The following is a description of a gene set: Human Gene Set: GSE13484_12H_VS_3H_YF17D_VACCINE_STIM_PBMC_DN Genes down-regulated in comparison of peripheral blood mononuclear cells (PBMC) cultured with YF17D vaccine for 12 h versus PBMC cultured for 3 h. studied in species Homo sapiens from publication Querec TD, Akondy RS, Lee EK, Cao W, Nakaya HI, Teuwen D, Pirani A, Gernert K, Deng J, Marzolf B, Kennedy K, Wu H, Bennouna S, Oluoch H, Miller J, Vencio RZ, Mulligan M, Aderem A, Ahmed R, Pulendran B (PMID 19029902) The immune responses generated by YF-17D by profiling genes in PBMCs from 2 donors cultured with YF-17D vaccine were accessed after 3 and 12 hours., and this is the list of marker genes: C4BPB (NCBI Gene Id 725), ETV7, EEF1B2, EIF3J, CD5, HBS1L, AHCTF1, RBPMS, TGFBI, TSPAN9, RAI1, KPNA1, SP100, DLL3, ICAM1, P2RX5, KLF2, ITGAM, DCAKD, PRDX6, CDKN2D, CYB5B, MYH2, MAP3K2, HLA-DMA, MAPRE2, SPTBN1, IL1R2, CNDP2, GPN1, TPSD1, EIF4A1, BAK1, ARID5A, TSC22D3, SAMD9, MGST2, POLR3E, MIA3, KLRB1, DENND5A (DENN domain containing 5A), CARTPT, ZBTB1, ISCA1, KLHL20, PPP1CB, PVALB, PICALM, VOPP1, H2AC4, RLF, RAB3GAP1, H2BC17, B4GALT1, CRYBG1, EPAS1, EEF1A2, VPS37B, DNAJA1, TAS2R3, HCAR3, TMEM39A, RGCC, TIPIN, NDUFA9, CYCS, CLASP2, OTUD7B, KIR2DL4, GP1BA, SFXN1, COX7B, PRSS53, ATP1A1, BTG2-DT, SNRK, ZNF124, RAB29, SYNCRIP, BCL2A1, CHN2, MYD88, TMX4, RPL5, CHP1 (calcineurin like EF-hand protein 1), MTPAP, RNF103, MTX1, UTP11, RHOBTB1, MAGT1, PSAP, DEAF1, KLHDC4 (kelch domain containing 4), NFYC, AP3M2, IL4R, PSMD12 (NCBI Gene Id 5718), CCZ1B, CAMK1D, KCNIP1, STAT3, CEMP1, TULP2, RPL3, RACK1, SERPING1, RIF1, STAT4, RPL8, CLEC2D, SEH1L, DDX50, AKAP7, GNAZ, MALT1, ENDOD1, MARCHF2, RPSA, PECAM1, TOR1B (NCBI Gene Id 84822), MTHFD2L, B4GALT5, HIVEP1, RAP1GAP2, PIM1, PGK1, ZCCHC14, SCPEP1, S100A6, REPS2 (NCBI Gene Id 9185), IL18R1, PXN, ERCC6L, GBP2, SLC25A32, SH2B3, ARL4C, CD36, GSPT1, CAVIN2, GPR65, PRNP, MIR22HG, PMAIP1, IL1A, IRGQ, MST1R, RUVBL1, WARS2, RUFY1, GUSB, CYP4F8, SLC25A6, TLE3, ABCB4, BTAF1, PCK1, KDM6B, ECD, LMO4, CISH, MTR, TNFSF14, NR4A2, ZC3H13, GJC2, RAB4A, RBM12, LAIR2, KLF4, REG3A (regenerating family member 3 alpha), DEFB1 (defensin beta 1), ADCYAP1, PARP4, AFTPH, GBP1, HP, HMCES, GPR18, MPC1, TGIF1, ZNF200, TFDP2, ZNF276, CMAHP (NCBI Gene Id 8418), BCOR, CARHSP1, RASGRP1, CDKL1, SEL1L, MYO6, SLC10A3, CCDC93, HNRNPM, FUS, MAD1L1, HLA-DPB1, PITPNB, SCAF4